Given this list of marker genes HMGB1, ABL1, NEIL3, BLM, ERCC5, RECQL4, WRN, XPC, here is a description of the gene set: Binding to DNA segment that contains a bubble. A bubble occurs when DNA contains a region of unpaired, single-stranded DNA flanked on both sides by regions of paired, double-stranded DNA. species: Homo sapiens Human Gene Set: GOMF_BUBBLE_DNA_BINDING